The following is a description of a gene set: species: Mus musculus Catalysis of the reaction: a nucleoside diphosphate + H2O = a nucleoside monophosphate + phosphate. Mouse Gene Set: GOMF_NUCLEOSIDE_DIPHOSPHATE_PHOSPHATASE_ACTIVITY, and this is the list of marker genes: Cant1, Gbp2, Pgp, Nudt18, Entpd3, Entpd2, Entpd5, Entpd4b, Entpd7, Entpd6, Entpd4, Alpl, Nudt15, Nudt16, Entpd1, Entpd8, Gbp2b, Nudt5, Slc25a42